Given this list of marker genes SLC15A4, TASL, RSAD2, DDX3X, TREML4, here is a description of the gene set: species: Homo sapiens Any process that activates or increases the frequency, rate, or extent of toll-like receptor 7 signaling pathway. Human Gene Set: GOBP_POSITIVE_REGULATION_OF_TOLL_LIKE_RECEPTOR_7_SIGNALING_PATHWAY